The following is a description of a gene set: Any endocytosis that is involved in the uptake of a virus into a host cell. species: Homo sapiens Human Gene Set: GOBP_ENDOCYTOSIS_INVOLVED_IN_VIRAL_ENTRY_INTO_HOST_CELL, and this is the list of marker genes: JPT2, KIAA0319L, DPP4, PIKFYVE, RNASEK (NCBI Gene Id 440400), CAV2, CAV1, CTSL, CLEC4M, EPS15, SIGLEC1, TPCN2, ACE2 (NCBI Gene Id 59272), TPCN1